The following is a description of a gene set: studied in species Homo sapiens The process aimed at the progression of an enucleate erythrocyte over time, from initial commitment of the cell to a specific fate, to the fully functional differentiated cell. Human Gene Set: GOBP_ENUCLEATE_ERYTHROCYTE_DEVELOPMENT, and this is the list of marker genes: MED1, HDAC6, NEMP1, RAC2, TRIM58, MAEA, RAC1, DIAPH3 (NCBI Gene Id 81624)